The following is a description of a gene set: species: Mus musculus Mouse Gene Set: GOBP_ADENYLATE_CYCLASE_INHIBITING_DOPAMINE_RECEPTOR_SIGNALING_PATHWAY An adenylate cyclase-inhibiting G protein-coupled receptor signaling pathway initiated by dopamine binding to its receptor, and ending with the regulation of a downstream cellular process., and this is the list of marker genes: Flna, Prmt5, Adcy5, Drd4, Drd3, Drd2